The following is a description of a gene set: Mouse Gene Set: GOMF_PHOSPHATASE_INHIBITOR_ACTIVITY Binds to and stops, prevents or reduces the activity of a phosphatase. studied in species Mus musculus, and this is the list of marker genes: Ppp1r27, Ppp1r10, Elfn1, Tiprl (NCBI Gene Id 67837), Ppp1r1c, Ppp1r14bl, Anp32e, Sirpa, Ppp1r17 (NCBI Gene Id 19051, protein phosphatase 1, regulatory subunit 17), Ppp1r11, Mgat5, Smtnl1 (smoothelin-like 1), Ywhab, Arpp19, Ppp1r37, Styx-ps, Tescl (tescalcin-like), Ppp1r14a, Ppp1r14b, Sh3rf2, Ensa, Igfbp2, Ptn, Ppp1r9b, Uri1, Ppp1r14d, 2810408A11Rik, Ppp1r2, Ppp1r14c, Ywhae, Ppp4r4, Pabir2, Tmem225, Rcan1, Pabir1, Tprn, Ppp1r1b, Cry2, Styx, Tesc, Lmtk2, Ppp1r1a, Ppp1r26, Phactr4, Cmya5, Hsp90b1, Styxl1, Sbf1, Phactr1, Bod1, Myoz1, Ppp1r36, Ppp1r8, Elfn2, Cabin1, Phactr3, Cip2a, Ppp1r35